The following is a description of a gene set: studied in species Homo sapiens A goiter that is not associated with functional thyroid abnormalities. Human Gene Set: HP_EUTHYROID_GOITER Euthyroid goiter, and this is the list of marker genes: EYA1, PDE11A, DICER1, SIX1 (SIX homeobox 1), SIX5, PRKAR1A